The following is a description of a gene set: Mouse Gene Set: GOBP_NEGATIVE_REGULATION_OF_SODIUM_ION_TRANSMEMBRANE_TRANSPORT species: Mus musculus Any process that stops, prevents or reduces the frequency, rate or extent of sodium ion transmembrane transport., and this is the list of marker genes: Pcsk9, Nherf1, Agrn, Grp, Commd1, Camk2d, Nedd4, Stk39, Nedd4l, Osr1